Given this list of marker genes NECTIN3, CDH4, AMIGO3, CBLN1, ICAM1, NECTIN1, AMIGO1 (adhesion molecule with Ig like domain 1), PSG11, SELL, HMCN1, VCAM1, UMOD, REG3A, NRXN1, CRB1, GRID2 (NCBI Gene Id 2895), PVR, CD164, FAT4, CEACAM5 (CEA cell adhesion molecule 5), CRB2, PSG5, ITGA5, AMIGO2, JAML, CADM1, PTPRD, IGSF21, CEACAM8, CXADR, ALCAM, CRTAM, NLGN1, CD6, CEACAM6, CADM3, CD209, SCARF1, SELE, LGALS7B, CDH2, ITGAL, SELP, NECTIN4, DCHS1, PSG2, SCARF2, here is a description of the gene set: studied in species Homo sapiens The attachment of an adhesion molecule in one cell to a nonidentical adhesion molecule in an adjacent cell. Human Gene Set: GOBP_HETEROPHILIC_CELL_CELL_ADHESION_VIA_PLASMA_MEMBRANE_CELL_ADHESION_MOLECULES